Given this list of marker genes Apoc1, Pnliprp2, Gdpd3, Plb1, Pla2g15, Pla2g5, Pla2g7, Pla2g10, Pnpla7, Pla2g4a, Enpp2, Ldlr, Scarb1, Pnpla8, Pla2g6, here is a description of the gene set: The chemical reactions and pathways resulting in the breakdown of phosphatidylcholines, any of a class of glycerophospholipids in which the phosphatidyl group is esterified to the hydroxyl group of choline. Mouse Gene Set: GOBP_PHOSPHATIDYLCHOLINE_CATABOLIC_PROCESS studied in species Mus musculus